Given this list of marker genes CNOT7, CAMK2N2, NSD2, FHL1, CAMK2G, NTRK3, H3-3B, PHACTR3, USP6 (ubiquitin specific peptidase 6), SFSWAP, DNAL4, TMOD1 (tropomodulin 1), SON, SLC6A8, RB1CC1, ZDHHC5, DAG1, MTA2, AMBRA1 (autophagy and beclin 1 regulator 1), UTP14A, QKI, SYNPO2, RIOK3, PHF20L1, ZNF382, HIVEP2 (HIVEP zinc finger 2), RCAN2 (NCBI Gene Id 221402), MED1, HYCC2, PDCD7, IL1RL1, NEUROG1, SETD2, RBAK, SRSF1, USP46, CPEB3, WDR44 (WD repeat domain 44), VAMP2, KPNB1, USP32P2, H3-5, GDF3, SRSF5, ACE, PKNOX2, MLLT6, ODF2, VEZF1, DOCK3, MAP2, RBM3, UBE2J2, PLXNA1, RAB10 (NCBI Gene Id 51140), ZNF212, RNF4, DDX54, HIC2, MXD4, SATB1, XPO1 (NCBI Gene Id 7514), OGT, IGF1, NEK9, R3HDM1, here is a description of the gene set: Human Gene Set: AGGAGTG_MIR483 Genes having at least one occurence of the motif AGGAGTG in their 3' untranslated region. The motif represents putative target (that is, seed match) of human mature miRNA hsa-miR-483 (v7.1 miRBase). studied in species Homo sapiens